The following is a description of a gene set: Mouse Gene Set: GOBP_ENDOPLASMIC_RETICULUM_TUBULAR_NETWORK_ORGANIZATION A process that is carried out at the cellular level which results in the assembly, arrangement of constituent parts, or disassembly of the endoplasmic reticulum (ER) tubular network. The ER tubular network is the ER part that that has membranes with high curvature in cross-section. species: Mus musculus, and this is the list of marker genes: Atl2, Use1, Dmtn, Atl3, Reep3, Reep4, Zfyve27, Rtn2, Rtn3, Rab18, Rtn4, Arl6ip1, Atl1, Lnpk, Tmem33, Reep1, Rtn1, Rab3gap1, Rab10, Retreg3, Rab3gap2, Reep2, Tmem170